The following is a description of a gene set: species: Mus musculus The directed movement of the mitochondrion to a specific location, by a process involving microtubules. Mouse Gene Set: GOBP_ESTABLISHMENT_OF_MITOCHONDRION_LOCALIZATION_MICROTUBULE_MEDIATED, and this is the list of marker genes: Mgarp, Agbl4, Agtpbp1, Sybu (NCBI Gene Id 319763), Mapt, Kif1b, Kifbp, Map1b, Fez1, Map6, Rhot1, Uchl1, Trak1, Hsbp1, Nefl, Trak2, Armcx3, Actr10, Kif5b, Spast, Hdac6, Wasf1, Hif1a, Ubb, Rhot2